Given this list of marker genes HILPDA, LIMK2, CRISP2, SLC7A6OS, NATD1, WDR73, EPHB3 (NCBI Gene Id 2049), ZFPM1, GPN3, MAPDA, MSH6, ZNF263, DEF6, CDAN1, ZFP64, SAP30BP, FAM220A, CLDN2, HMGCL, TWIST2, ICAM1, PIDD1, L3HYPDH (trans-L-3-hydroxyproline dehydratase), SLC25A12, TP53RK, TMEM41A, SHISAL2B, CAMLG, RAP2B, BRINP1, NAA30, FASTKD3, CMTM6, DUSP11, MRPS31, FGF18, OTUD4, FDXR, MRM1, ZFYVE21, PIGF, PNP, NSMCE2, PTCD1, PPP2R5D, GMIP, IFT43, ISG20, DEPDC7, SAC3D1, TEPSIN, DFFB, DDIT3, ARVCF, TTC23, SH3YL1, TRBV13, ULK1, KNOP1, USP27X, TAS1R2, PTK2, MTERF4, OVGP1, CCNT1, CHST11 (NCBI Gene Id 55807), ARMC10, TRIM13, SEC24D, OR2H2, IMP3, BTG1, ZXDC, KIN, DDX41, DCAF4, FBRS, DYRK3, ZNF622, BTG2, RPRM, ATP23, CLUAP1, TRAF4, C10orf88, POLR1E, TGIF1, SAP30, RBM43, FBXO17, LPIN1 (NCBI Gene Id 23175), GPR84, MTRES1, CASP6, TLE1, FCHSD1, PPM1D, SPRYD4, ELOVL5, here is a description of the gene set: Middle response genes: differentially expressed in the period between 3 h and 12 h after UV-C irradiation of MEF cells (embryonic fibroblast). studied in species Mus musculus Phosphorylation is important in p53-mediated DNA damage responses. After UV irradiation, p53 is phosphorylated specifically at murine residue Ser389. Phosphorylation mutant p53.S389A cells and mice show reduced apoptosis and compromised tumor suppression after UV irradiation. We investigated the underlying cellular processes by time-series analysis of UV-induced gene expression responses in wild-type, p53.S389A, and p53(-/-) mouse embryonic fibroblasts. The absence of p53.S389 phosphorylation already causes small endogenous gene expression changes for 2,253, mostly p53-dependent, genes. These genes showed basal gene expression levels intermediate to the wild type and p53(-/-), possibly to readjust the p53 network. Overall, the p53.S389A mutation lifts p53-dependent gene repression to a level similar to that of p53(-/-) but has lesser effect on p53-dependently induced genes. In the wild type, the response of genes to UV irradiation was strictly biphasic. The early stress response, from 0 to 3 h, results in the activation of processes to prevent the accumulation of DNA damage in cells, whereas the late response, from 12 to 24 h, relates more to reentering the cell cycle. Although the p53.S389A UV gene response was only subtly changed, many cellular processes were significantly affected. The early response was affected the most, and many cellular processes were phase-specifically lost, gained, or altered, e.g., induction of apoptosis, cell division, and DNA repair, respectively. Altogether, p53.S389 phosphorylation seems essential for many p53 target genes and p53-dependent processes. from publication Bruins W, Bruning O, Jonker MJ, Zwart E, van der Hoeven TV, Pennings JL, Rauwerda H, de Vries A, Breit TM (PMID 18195040) Human Gene Set: BRUINS_UVC_RESPONSE_MIDDLE